Given this list of marker genes PDGFRA, NRP1, FLT3, FLT4, FLT1, NRP2, KDR, here is a description of the gene set: Human Gene Set: GOMF_VASCULAR_ENDOTHELIAL_GROWTH_FACTOR_RECEPTOR_ACTIVITY Combining with a vascular endothelial growth factor (VEGF) receptor ligand and transmitting the signal across the plasma membrane to initiate a change in cell activity. species: Homo sapiens